The following is a description of a gene set: Any process that activates or increases the frequency, rate or extent of action potential creation, propagation or termination. This typically occurs via modulation of the activity or expression of voltage-gated ion channels. species: Mus musculus Mouse Gene Set: GOBP_POSITIVE_REGULATION_OF_ACTION_POTENTIAL, and this is the list of marker genes: Pawr, Tacr1, Scn5a, Ffar3, Rapgef4, Tnf, Kcnip1, Nps, Hnrnpa1, Slc9a1, Cntnap2, Gba1, Tac1, Ank3, Adra1a, Trpm4